Given this list of marker genes SEC24C, FKRP, BTD, ZSWIM6, CEP290, B3GALNT2, DLL3, FKTN (fukutin), GLB1, TMEM216, GNPTAB, NAXE (NCBI Gene Id 128240), SCAF4, DKK1, VANGL1, KIAA0586, GJA1, RREB1, NF2, WNT7A, GMPPB, SNRPB, TBX1, COL18A1, LFNG, GP1BB, COL2A1, INPP5E, ARSB (arylsulfatase B), LARGE1, FOXI3, POMGNT1, RASA1, GLI2, POMT2, UFD1, NMNAT1, SC5D, EXT1, PTCH1, SMO, HIRA, HES7, PIK3CA, TMEM237, HNRNPK, CYP27A1, CSPP1, NOTCH3, COMT, CRPPA, JMJD1C, EXT2, MESP2, CPLANE1, GALNS, PAX3, ARVCF, ABCD1 (ATP binding cassette subfamily D member 1), POMT1, RIPPLY2, here is a description of the gene set: Closed neural tube defect studied in species Homo sapiens A type of neural tube defect that is covered by skin. Human Gene Set: HP_CLOSED_NEURAL_TUBE_DEFECT